The following is a description of a gene set: part of: Diseases associated with glycosylation precursor biosynthesis Reactome Pathway: Defective GFPT1 causes CMSTA1 Glucosamine-fructose 6-phosphate aminotransferases 1 and 2 (GFPT1,2) are the first and rate-limiting enzymes in the hexosamine synthesis pathway, and thus formation of hexosamines like N-acetylglucosamine (GlcNAc). These enzymes probably play a role in limiting the availability of substrates for the N- and O-linked glycosylation of proteins. GFPT1 and 2 are required for normal functioning of neuromuscular synaptic transmission. Defects in GFPT1 lead to myasthenia, congenital, with tubular aggregates 1 (CMSTA1; MIM:610542), characterised by altered muscle fibre morphology and impaired neuromuscular junction development. Sufferers of CMSTA1 show a good response to acetylcholinesterase inhibitors. The missense mutations observed do not always result in significant reduction in enzyme activity, but biopsies show reduced amounts of GFPT1 protein suggesting increased turnover or defective translation. studied in species Homo sapiens, and this is the list of marker genes: GFPT1